The following is a description of a gene set: Reactome Pathway: Potassium transport channels studied in species Homo sapiens part of: Inwardly rectifying K+ channels Inwardly rectifying potassium transport are tetrameric channels that are found in kidney in the nephron. Kir 1.1 works as a homotetramer, however, Kir 4.1 and 5.1 work as heterotetramers. These channels transport K+ from cytosol to the lumen of the tubules., and this is the list of marker genes: KCNJ10, KCNJ16, KCNJ1